Given this list of marker genes GABRB2, BRAF, FYN, PTPN11, CDKN2A, TTI1, SHC1, PLCB1, MTOR, KRAS, RAF1, CPT1A, AKAP5, RAP1GAP, HCN1, MLST8, ARC, EIF4G1, MECP2, PTEN, EIF4A1, RPTOR, PRKACA, DLG4, AGO2, SH3GL3, KCND2, GAD1, ABCD3, PTPN5, PRKAR1A, CYFIP2, EIF4E, CLTB, CYFIP1, HOXB8, GAB1, AP2B1, AP2A1, EPHA4, DICER1 (NCBI Gene Id 4333), CAMK2A, MAP1LC3B, AKT1S1, PPP2R5B, EEF1A1, CLTCL1 (clathrin heavy chain like 1), PLCG1, GRIN1, GABRA1, APP, AP2S1, TSC2, MAPK1, GRIA1, GRIP2, GRB2, PPP3CA, AP2M1 (NCBI Gene Id 1173), PRKCA, SLC16A1, DNM2, PIK3CB, ITPR1, SH3GL1, GPHN, EPS8L1, DNM1, GABRG2, SRC, PICK1 (protein interacting with PRKCA 1), TECR (trans-2,3-enoyl-CoA reductase), GRIN2B, GRIN2A, GRM1 (NCBI Gene Id 2911), SOS1, CREB1, HOMER1, CLTC, ARAF, FMR1, CNR1, EIF4EBP2 (eukaryotic translation initiation factor 4E binding protein 2), CAMK1, MKNK1, MAP2K2, ALDH3A2, RHEB, NF1, PPP1CA, NTRK2, TBC1D7, RPS6KB1, SHANK1, GABRD, ABAT, CAMK2B, KCNC1, DUSP3, CLTA, MMP9, TARBP2 (TARBP2 subunit of RISC loading complex), DLGAP3, TELO2, AGAP2, DEPTOR, GRIA2, BDNF, AKT1, TSC1, GRIP1, MAP2K1, SLC6A1, ARHGAP32, PDK1, GRM5, DAG1, MAP1B, ALDH5A1, SYNGAP1, CAMK4, here is a description of the gene set: species: Homo sapiens Human Gene Set: WP_FRAGILE_X_SYNDROME Fragile X syndrome